Given this list of marker genes CD5, DECR1, MCOLN1 (NCBI Gene Id 57192), APOA2, FTCD, RHD, LCE3B (NCBI Gene Id 353143), BLMH, ST8SIA2, RPL36, STBD1, CAPN2, BICD2, INPP5B, SNAP23, POC5, DDX47, VPS72, GLIPR1, BEX4, THOC1, ADAP2, CHCHD3, FSIP1, SLAMF1, PPIL4, NAA15, RPP21, MCM5, ARMC7, TLR1, PCDHB2, USP2, GSTM5, LMCD1, ADNP2 (NCBI Gene Id 22850), GABRA3, TSSC4, PILRA (NCBI Gene Id 29992), QPCTL, NDUFB4, ANKRD17, TBCA, EIF2AK4, ADCY4, KEL, LCE2B (late cornified envelope 2B), MAP2K1, NOP10, CS, BBOX1, ANXA6, RANBP1, SMC6, B4GALT3, SLA, TP63, RIMKLB, ID2, FCAMR, KRTAP3-3, CCDC137, TMEM97, SURF6 (NCBI Gene Id 96491), CYBB, PSME3, CLDN3, PHLPP1 (NCBI Gene Id 23239), PTTG1IP, CLEC10A, POU2F2, PITX3, CHKA, ZNF23, KLF16, PMFBP1, TEX12, B3GALT5, MRPS33, MAF, TMEM144, ATP5F1E, HADH, IL27RA, CEACAM21, SUCO, PRPSAP2, GMNN, CLASP2, AQR, H2BC5, UQCC2, RAB2A, LRRC57, METRNL (NCBI Gene Id 653506), JUNB, NFKBIE, NOX4, PRODH, ABCG2 (NCBI Gene Id 9429), SLC25A4, PTH1R, ENPP1, FUNDC1, EPDR1, PLA2G10 (NCBI Gene Id 8399), FAM222B, GNG10, GADD45GIP1, SPTAN1, MITF, PAM, CLEC4M, CSDE1, DPP7, CDK5 (NCBI Gene Id 1020), IER3, BLOC1S4, GRIK5, MCM2, FCRL1, GYPC, NCF1, GCC1, POLR1D, TRAPPC13, PTPN1, PNO1, HCFC1R1, BRAF, EIF3K, PLA2G1B, PLG, SLX9, TMEM119, MAPK7, SMAD6, SURF4, TAF10, TIA1, ZCCHC9, SERPINA3 (NCBI Gene Id 95022), RUFY3, SLC20A1, RBMS1, HP, SNRPC, CASP1, PSMC2, PLPP7, TBC1D8, MRPL36, PEX6, DIO1, MINDY1, IRAK4, MCMBP (NCBI Gene Id 79892), VAMP4, PJA2, PPDPF, TAX1BP3, REST, NDE1, LHB, SSB (small RNA binding exonuclease protection factor La), TRIM39, RFNG, COPE, IVNS1ABP, ANAPC16, FOXO1, NAA10, PLEKHA5, GSX1, RAG1, LAMA5, RASD2, STAT4, SYT12, HBZ, HHEX, CD14, RTN4, PROCR, ZC3H12A, WARS1, CLYBL, NUDT5, TSKS, GPI, TESK1, SLC35A4, CDC25A, SOD2, MAP3K8, FOXRED1, ATP1B1, HBE1, OSBPL1A, here is a description of the gene set: mouse primary BMDCs were stimulated with tlr ligands and gene expression changes were profiled on Affymetrix arrays species: Homo sapiens Human Gene Set: GSE17721_LPS_VS_GARDIQUIMOD_0.5H_BMDC_UP Genes up-regulated in comparison of dendritic cells (DC) stimulated with LPS (TLR4 agonist) at 0.5 h versus DC cells stimulated with Gardiquimod (TLR7 agonist) at 0.5 h. from publication Amit I, Garber M, Chevrier N, Leite AP, Donner Y, Eisenhaure T, Guttman M, Grenier JK, Li W, Zuk O, Schubert LA, Birditt B, Shay T, Goren A, Zhang X, Smith Z, Deering R, McDonald RC, Cabili M, Bernstein BE, Rinn JL, Meissner A, Root DE, Hacohen N, Regev A (PMID 19729616)